The following is a description of a gene set: Reactome Pathway: Anchoring of the basal body to the plasma membrane studied in species Homo sapiens Cilium biogenesis is initiated by the docking of basal bodies, a centriole-derived organelle, to the plasma membrane. The centriole consists of a multiprotein core surrounded by a ring of nine microtubule triplets; the mother centriole additionally has 'distal' and 'subdistal appendages' that are critical for ciliogenesis. Basal bodies initiate and anchor the extension of the axonemal microtubules and also associate with secretory vesicles which are thought to provide membrane components for the extension of the ciliary membrane. Basal bodies are attached to the plasma membrane through a proteinaceous network of transition fibers that form part of the 'transition zone' at the ciliary base. The transition zone acts as a selective barrier or ciliary pore, excluding vesicles and limiting the diffusion of proteins and lipids from the cytosol or plasma membrane. In addition to the transition fibres, the transition zone also consists of the ciliary necklace (a row of protein particles at the ciliary membrane at the base of the cilium) and the Y-links (that connect the axonemal microtubules to the membrane at the ciliary necklace). part of: Assembly of the 9+0 primary cilium, and this is the list of marker genes: YWHAG, CEP89, SDCCAG8, CEP83, HSP90AA1, ALMS1, CEP162, TMEM67, YWHAE, CEP43, B9D2, CDK5RAP2, HAUS2, C2CD3, IQCB1, CEP72, CEP78, CDK1, RPGRIP1L, DCTN2, TUBB4B, TUBG1, CCP110, NPHP1, MAPRE1, MARK4, TCTN2, SFI1, HAUS4, CSNK1E, NEDD1, HAUS8, RAB8A, CLASP1, CEP152, CEP70 (NCBI Gene Id 80321), CKAP5, CEP97, RAB3IP, TUBB, CEP192, HAUS3, NEK2, FBF1, CEP131, TUBA4A, TUBB4A, PRKAR2B, CEP250, NDE1, CEP164, SEPTIN2, MKS1, PPP2R1A, CPAP, OFD1, TTBK2, DYNC1H1, PLK1, TCTN3, ODF2, CEP135, CEP41, TCTN1, CEP76, PAFAH1B1, CSNK1D, CEP63, DYNC1I2, HAUS1, HAUS7, HAUS5, DCTN1, NINL, SCLT1, CEP290, DYNLL1, AHI1, SSNA1, TUBA1A, PRKACA, PCNT, B9D1, CEP57, NPHP4, KIF24, CC2D2A, RAB11A, PCM1, DCTN3, HAUS6, TMEM216, AKAP9, CNTRL, CETN2, PLK4, ACTR1A